Given this list of marker genes ECHDC2, PLCG1, CYTH1, PRMT7, HNRNPLL, KLF12, RPS3, BAG3, GOLGA7B, SEPTIN1 (septin 1), SPTAN1, REM2, CD3D, PCNX2, GPR183, RASGRF2, LY9, DYRK2, MRPL41, FAM171A1, FBLN7, CD84, OPTN, NOSIP, SLC39A13, CD3E, RPL34, SPOCK2, PBXIP1, ITM2A, TTC39C, SIRPG, ACVR1 (NCBI Gene Id 90), PRKCQ, CCND2, NSMCE3, RUVBL1, PAG1, TRAF2, ARHGEF18, AMMECR1, CASP6, TMEM14A, RGCC, TRBC1, CD82, ICOS, ARID4B, TNFSF8, GPX7, GOLGA2P5, BICDL1, ATIC, WWP1, MTHFD1L, PATJ, CBX7, RCAN3, OCIAD2 (OCIA domain containing 2), VOPP1, MEGF6, LRIG1, KCTD2, EPHA4, INPP4B, HAPLN3, CDC14A, SFXN1, GALNT12, ENSG00000284691, TLE5, PELP1, GOLGA7, KIF22, MAST4, ZNF101, BCL9L, PPP1R35, KMT2A, SMYD2, ZNF512B, ENSG00000291149, PPP3CC, CD6, MRTFB, SH2D1A, TRAC, FAM226B, ITGB1 (NCBI Gene Id 3688), EVL, MAF, PRKCH, NFRKB, TRAF5, UBASH3A, RTTN, PLAAT4, MAP3K14, LIME1, ITK, DEXI, MLLT3, PRKCQ-AS1, EML4, ACSL6, HECA, ZNF862, REXO2, LDHB, PRPS1 (phosphoribosyl pyrophosphate synthetase 1), ANXA2R, JADE2, TAF9B, RNF126, HINT1, FBXL16, TC2N, HMOX2, LSR, TECR, XPC, CD28, ZBTB25, EIF5B, PVT1, DOCK9, NIPAL3, GATA3, CYB561D1, S1PR1, MZT2B, RPL3, BIN1, ANKH, CAMK2G, TSPYL4, ESYT1, FAM117A, PHC1, ST3GAL1, EDEM1, LCK, KIAA0586, SLC2A4RG, CD96, PHACTR2, RRP1B, SUSD3, SUPT20H, FAAH2, ATP8B2, ISYNA1, VSIG1, PRDX2, ANO9, USP20, LRATD2, ACAT2, CD5, NAE1, STMN3, PNMA1, RASGRP1, FBXL8, TRAT1, RHBDD2, FBXO31, EPB41, ST8SIA1, PBX4, CFAP36, DDX24, CDR2, PRIM1, SLC26A11, PLCD1, ZNFX1, TENT4A, FAM107B, PSIP1, AQP3, SIGIRR, CASK, PHF1, TMC6, CD2, SLC9A3-OT1, THUMPD1, C12orf57, SYNRG, GSTK1, ITPR3, STAT5B, RNF214, TMEM63A, ZFP90, NSUN5P1, CD40LG, here is a description of the gene set: species: Homo sapiens from publication Abbas AR, Wolslegel K, Seshasayee D, Modrusan Z, Clark HF (PMID 19568420) Human Gene Set: GSE11057_PBMC_VS_MEM_CD4_TCELL_DN Genes down-regulated in comparison of peripheral mononuclear blood cells (PBMC) versus memory T cells. Microarray deconvolution is a technique for quantifying the relative abundance of constituent cells in a mixture based on that mixture's microarray signature and the signatures of the purified constituents. It has been applied to yeast and other systems but not to blood samples. Here we test the ability of this technique to determine the fractions of subsets of memory T cells in peripheral blood mononuclear cell (PBMC) samples.